The following is a description of a gene set: Human Gene Set: GOBP_RESPONSE_TO_AMPHETAMINE species: Homo sapiens Any process that results in a change in state or activity of a cell or an organism (in terms of movement, secretion, enzyme production, gene expression, etc.) as a result of an amphetamine stimulus. Amphetamines consist of a group of compounds related to alpha-methylphenethylamine., and this is the list of marker genes: DBH, HDAC6, DRD1, RGS4, SOD1, PDE1B, DRD5, EDNRA, ASIC1 (NCBI Gene Id 41), NR4A2, RGS17, CALM3, RGS2, RANBP2 (NCBI Gene Id 5903), OXT, FOSB, GNAL, PPP1R9B, HPRT1, GRIN2A, DRD2, DRD4 (dopamine receptor D4), PPP1R1B, SLC18A2, RGS9, EDN1, ADORA2A, HDAC2, COMT, CNR2 (NCBI Gene Id 1269), SLC1A1